The following is a description of a gene set: studied in species Mus musculus from publication Chen Y, Wang X (PMID 31504780) Mouse Gene Set: MIR_5615_5P Genes predicted to be targets of miRBase v22 microRNA mmu_miR_5615_5p in miRDB v6.0 with MirTarget v4 prediction scores > 80 (high confidence targets)., and this is the list of marker genes: Stim1, Rpl41, Socs2, Sh2d4a, Psmb11 (proteasome (prosome, macropain) subunit, beta type, 11), Phf21a, Rnf6, Shroom4, Snai2, Kcnv1, Champ1, Ms4a6c, Ankrd50, Clec4e, Asb8, Ranbp17, Fign, Lurap1l, Dusp10, Zfp612, Rad23b, Magt1, Fstl1, Snx7, Ino80, Tmed5, Pcgf5, Crebrf, Afg3l2, Kcmf1, Csnk1a1, Rpp40, Zmym5, Adra2c, Arid1a, Arpc5, Tspan18, Hacd2, Nrbf2, Gm2042, Borcs8, Oprd1, Apln, Stk3, Pfn2, Cdh8, Rhobtb1, Dynlt1b, Dio2, Vwc2l, Pgrmc2, Mier3, Dcp1a, Exosc1, Slc12a2 (NCBI Gene Id 20496), Cpne4, H2az1, Eeig1, Nfatc1, Usp31, Ugcg, Fbn1, Dnajc6, Lin28b, Nlk, Ifrd2, Tgfbr2, Slc35f3, Sema5a, Jph1, Pla2r1, Efcab14, Cpeb1, Iqcg, Kcnma1, Tecta, Banp, Fgf10, Cxxc5, Cdnf, Ccdc160 (coiled-coil domain containing 160), Tgm3, Cpsf6, Gorasp2, Max, Tapt1, G3bp2, Megf10, Sult1c2, Ark2c, Arhgef38, Spry2, Ms4a6b, Pwwp3b, Zbtb34, Dio1, Hic2, Lpar4, Acsl1, Phldb2, Lrrc74b, Atp8b4, Prkaa2, Scrib (NCBI Gene Id 54559), Kctd6, Ccdc30, Msi2, Napb, Lpgat1, Rabgap1l, Pcdh18, Mical2, Pmp22, Ube3c, Wls, Ptp4a2, Mtmr4, Lrrn3, Kcnd3, Adgra1, Csgalnact1 (chondroitin sulfate N-acetylgalactosaminyltransferase 1), F830045P16Rik (NCBI Gene Id 277435), Fbxl3 (F-box and leucine-rich repeat protein 3), Igf2r, Ranbp9, P4ha2, Npy1r, Pycr1, Ntng1, Erf, Cd59a, Pak4, Sptlc2, Gabrb2, Btc, 3830403N18Rik, Satb2, Nedd9, Crocc2, Lrrtm3, Rb1, Crim1, Nr2f6, Ralbp1, Kdm4a, Nap1l1, Pou2f1, Lgr4 (NCBI Gene Id 83944), Inhbb, Tead1, Mbnl3, Sorl1, Jazf1, Zcchc8, Cfhr1, Slmap, Oxsr1, Aff4, Ccng1 (cyclin G1), Clint1, Mrpl53, Tent5c, Rnf24, Cd22, Mllt3, Onecut2, Pou2f2